The following is a description of a gene set: Semaxanib, also known as SU5614, is an investigational type I tyrosine kinase inhibitor with activity against a wide range of receptor tyrosine kinases. It is not currently approved for clinical use. This pathway describes FLT3 mutants that show resistance to semaxanib-mediated inhibition. Reactome Pathway: semaxanib-resistant FLT3 mutants part of: Drug resistance of FLT3 mutants species: Homo sapiens, and this is the list of marker genes: FLT3